Given this list of marker genes RAPGEF5, SPON2, CA9 (carbonic anhydrase 9), POGLUT2, HIC1, CTC1, SOX1, AIM2, FMNL2, TINF2, CEP85, IFT88, SLC1A7, EXTL1, RHOBTB1, NRDE2, FLYWCH2, SLC44A3, PRKCD, IFT74, AHSA1, SCIN, EIF2AK4, NUAK2, BMP8A, IFIT1B, FLNC, TNNI3, ARRDC4, FRMD5, LTBR, FPR2, LDLRAD3, RLN1, GPN1, HAP1, RRAD, TBC1D9, AGT, ANKRD49, CBFA2T3, DEXI, DCLK3, RHBDL2, GPSM3, USP12 (NCBI Gene Id 219333), HIC2, BMPR2, MTMR14, NFIX, B4GALNT2, DPP7, ASNSD1, SLC8B1, GADD45B, CLUAP1, C3orf70, HTRA2, NAIF1 (NCBI Gene Id 203245), JUN (Jun proto-oncogene, AP-1 transcription factor subunit), SREBF2, FAM114A1, NECAP2, NPB, SPATA9, UNC93B1, FXYD2, ERLIN1, GUCY2C, TLR3, DUSP16, MFSD12, DCLRE1A, TSPO2, OSGEP, NFKBIE, MYO1H, RAB43, NUP62, ITPRIPL2, CDKN2B, VANGL2, HCN3, RBM38, TCF15, FAM98C, STAU2, SLC16A14, AMZ2, MYO5A, IFT46, GPR35, JUNB, DSCAM, EFEMP1, POP1, MLH3, RADIL, SPIC, MX1, IER5, SNX9, CRYZ, DEPP1, LRRN4CL, IRF6, TRIQK, SYT6, AGO4, EXT1, DENND3 (DENN domain containing 3), PLA2G4D, AKR7A2, VAV2, AKAP7, TPPP3, PPHLN1, REL, CMTM8, METTL3, CLEC7A, PTMS, STAP1, SLC30A4 (NCBI Gene Id 7782), HLCS, SLC6A12, PPP1R8, DUSP12, STIMATE, TEX14, RENBP, JARID2, AGPAT4, AIFM3, PCDH11X, GTF2IRD1, RALB, PLCG1, TAX1BP3, USP6NL, MRPS2, ATRNL1, RALGPS2, CDH26, GABRR1, MGARP, NXPE2, PTS, DYNC2I2, ACSL1, DCP2, COL27A1, ZFPM2, IKZF4 (NCBI Gene Id 64375), SERPINC1, N4BP2L1, PROS1, CHKA, GAL3ST1, IMPDH2, MRC2, MSMO1 (methylsterol monooxygenase 1), TOMM7, STARD5, METTL5, TMED1, HAUS8, EPB41L2, CLEC1A, TNFAIP8, RTCB, DNALI1, GMPPA, H2AC18, TMPO, PIK3CB, MFSD6L, MVD (mevalonate diphosphate decarboxylase), RALA, ITPRIP, SUPT3H, TYR, CDC42BPB, PCYT1A, KRTAP20-2 (NCBI Gene Id 337976), KRTCAP3, NUPR1 (nuclear protein 1, transcriptional regulator), APOA4, FAM3B, NECTIN4, SLC7A5, NDST1, MACROH2A1, RRAGC, AHRR, PRXL2B, HPSE, GFPT1, MRPS25, RNF19B, here is a description of the gene set: To obtain insight into the genetic basis of the increase of functional activity of memory B cells over time, we compared the gene expression profiles of day 7 and day 40 NP-specific/IgG1 memory B cells, GC B cells and plasma cells in immunized WT mice and naïve B cells, before and after activation in vitro. Human Gene Set: GSE11961_MARGINAL_ZONE_BCELL_VS_GERMINAL_CENTER_BCELL_DAY40_DN studied in species Homo sapiens Genes down-regulated in marginal zone B cells versus day 40 germinal center B cells. from publication Kaji T, Ishige A, Hikida M, Taka J, Hijikata A, Kubo M, Nagashima T, Takahashi Y, Kurosaki T, Okada M, Ohara O, Rajewsky K, Takemori T (PMID 23027924)